The following is a description of a gene set: species: Mus musculus Mouse Gene Set: GOBP_BONE_TRABECULA_MORPHOGENESIS The process of shaping a trabecula in bone. A trabecula is a tissue element in the form of a small beam, strut or rod., and this is the list of marker genes: Col1a1, Ext1, Cyp27b1, Fgfr3, Vegfa, Rhoa, Grem1, Sfrp1, Ppargc1b, Vdr, Wnt10b, Enpp1, Chad, Sema4d, Sbno2, Fbn2, Mmp2, Thbs3, Msx2